Given this list of marker genes PCDH18, PKP3, HS6ST2, SPRED3, DMD, LRFN1, INSM1, PRPF6, TMPRSS3, CSMD1, PLEKHO1, HPS4, OPN1LW, RAB5B, DLEU7, SEMA4A, SUN3, PQBP1 (polyglutamine binding protein 1), CD3D, KLHL29, LRRC23, HPX, CDH10, DOCK3, SULT4A1, SNX16 (sorting nexin 16), TM6SF2, RAD9A, CD72, MCM2, TSPAN9, TBR1, NMBR, BICDL2, PLEKHS1, SLC38A4, MEIOB, RAD51B (RAD51 paralog B), CHRNB2, PRR16, NUDT17, TNFAIP6, MAPK8IP2, NDRG4, ATP6V0E2, BMPER, LIMK1, KCNS2, NBL1, MKRN2, NRG3, GPR83, SCN2A, RPP25 (NCBI Gene Id 54913), YIF1B, HTRA1, IRF4, MLXIPL, C19orf33 (NCBI Gene Id 90521), SCN2B, CDH8, SERTM1, UNC13C, MLLT1, ST8SIA2, ZMAT2 (NCBI Gene Id 153527), FXYD1, KCNK6, GPRIN3, PRKCZ, CAVIN1, P3H2, UBE2E2, PLAG1, GPR151, STAT5A, MCF2L, NFAT5, CFAP91, PRLR, ZFP14, HERPUD1, CFAP52 (cilia and flagella associated protein 52), CLCF1, KCTD21, C5orf22, MAP9 (NCBI Gene Id 79884), SIX4, STAP2, CNST, ADORA3, SLC5A6, GRK1, LHX6, TJP2, GABRE, TMEM52B, PHKA1, ARPIN, RHBG, MOB3A, ARC, ADAMTS19, ARHGAP36, NR2F2, SPZ1, HLA-DOA, WNT5B, CBX2, STPG4, INSRR, TMEM120B, DEPDC1B, GADD45B, AMPH, MIF4GD, GJC3, ANXA10, C1orf210, TCEAL1, ADGRG6, PIK3R5, EFEMP1, KLRG2, IZUMO1, AASS, SUSD4, CYTH1, LUZP1, CLDN16, CAMKV, MTRFR, CHODL, FNDC5, AHSP, CREBL2, FAM163A (NCBI Gene Id 91000), BATF3, RHBDL2, ANKRD54 (NCBI Gene Id 129138), COG1, ZNF616, ZNF496, CACNA1C, PGR, SH3RF2, ARHGEF33 (Rho guanine nucleotide exchange factor 33), KLF17, EEF2K, SOD3, PDCD1LG2, DGKE, CFAP300, C9orf152, LARGE1 (NCBI Gene Id 9215), EYA1, SGPP2, EBF1, COLEC10, ALX1 (NCBI Gene Id 8092), PMVK, PPP1R3A, GPRC5A, NAPSA, PPARGC1A, KCNH5, SMTN (NCBI Gene Id 6525), ROR2, GIT2, PLPPR4, FBXO7, INTS3, CLCA2, SLC25A53, WNT11, SLC22A14, ANGEL2, GABRA4, MKRN1 (makorin ring finger protein 1), PANK4, CALHM5, MYOCD, DHX35, CAVIN2, SLC25A45, CYP27A1, GTSF1, CMYA5, PGAP6, MEGF11, SCRN1, BEND6, RNF133, TBX20, CLDN2 (NCBI Gene Id 9075), OR52N4, ACVR1C, TMEFF1, YARS1, TSHZ3, here is a description of the gene set: from publication Gattinoni L, Lugli E, Ji Y, Pos Z, Paulos CM, Quigley MF, Almeida JR, Gostick E, Yu Z, Carpenito C, Wang E, Douek DC, Price DA, June CH, Marincola FM, Roederer M, Restifo NP (PMID 21926977) Human Gene Set: GSE23321_CD8_STEM_CELL_MEMORY_VS_CENTRAL_MEMORY_CD8_TCELL_UP An early-differentiated CD8+ memory T cell subset with stem cell-like properties (TSCM) can be identified within the naïve-like T cell population by the expression of CD95/Fas. Based on experiments including exon- and gene-level expression analysis, we provide evidence that this subset of antigen-specific cells represents an early precursor of conventional central (TCM) and effector (TEM) memory CD8+ T cells with enhanced self-renewal capacity and proliferative potential. We identified genes differentially expressed between major T cell subsets defined along with memory T cell commitment. Based on the analysis of these genes, CD95+ naïve T cells (TSCM) cluster closer to the CD8+ T memory compartment than to classical (CD95-) naïve T (TN) cells, and display an intermittent phenotype between classical TN and TCM cells in terms of all major T cell differentiation markers analyzed. Genes up-regulated in CD8 T cells: stem cell memory versus central memory. studied in species Homo sapiens